The following is a description of a gene set: This event has been computationally inferred from an event that has been demonstrated in another species.<p>The inference is based on the homology mapping from PANTHER. Briefly, reactions for which all involved PhysicalEntities (in input, output and catalyst) have a mapped orthologue/paralogue (for complexes at least 75% of components must have a mapping) are inferred to the other species. part of: Downstream signaling of activated FGFR1 Reactome Pathway: SHC-mediated cascade:FGFR1 studied in species Mus musculus electronically inferred by orthology from the curated human pathway, and this is the list of marker genes: Grb2, Fgfr1, Fgf23, Fgf8, Fgf10, Shc1, Fgf1, Fgf22, Fgf4, Hras, Fgf20, Fgf2, Fgf5, Fgf6, Fgf17, Kl